Given this list of marker genes GEMIN4, GEMIN2, SMN1, NPAT, GEMIN6, ZPR1, DDX20, GEMIN7, SMN2, GEMIN5, GEMIN8, HABP4, here is a description of the gene set: Human Gene Set: GOCC_GEMINI_OF_CAJAL_BODIES Nuclear bodies frequently found near or associated with Cajal bodies (also called coiled bodies or CBs). Gemini of coiled bodies, or 'gems', are similar in size and shape to CBs, and often indistinguishable under the microscope. Unlike CBs, gems do not contain small nuclear ribonucleoproteins (snRNPs); they contain a protein called survivor of motor neurons (SMN) whose function relates to snRNP biogenesis. Gems are believed to assist CBs in snRNP biogenesis, and to play a role in the etiology of spinal muscular atrophy (SMA). species: Homo sapiens